The following is a description of a gene set: species: Mus musculus Genes predicted to be targets of miRBase v22 microRNA mmu_miR_6373 in miRDB v6.0 with MirTarget v4 prediction scores > 80 (high confidence targets). Mouse Gene Set: MIR_6373 from publication Chen Y, Wang X (PMID 31504780), and this is the list of marker genes: Rusc1, Tmem245 (transmembrane protein 245), Tsc1, Srprb, Smim17, Fgfr1op2, Nkapd1, Mrgpra3, Ccnc, Lrfn5, Zfp287, Bms1, Klf1, Ncam2 (NCBI Gene Id 18257), Trim30a, Impact, Spag16, Ablim3, Oosp1, Hagh, Tub, Rgs5, Capn6, Tm4sf4, Grin2b, Sh3bgrl, Thrb, Zfhx3, Slc38a1, Golga5, Neurog2, Acbd5, Igll1 (immunoglobulin lambda-like polypeptide 1), Faf1, Usp43 (ubiquitin specific peptidase 43), Nptx1, Pcgf3, Kmt5b, Abitram, Myh10, Bmp15, Twf1, Sp4, Gpr141b, Rad51ap1, Hook3, Thsd7b, Tmem106b, Lancl3, Clcn5, Dach2, Virma, Lgi1, Ska2 (spindle and kinetochore associated complex subunit 2), Rnf19a, Gng2, Trabd2b, Camk4, Ndst2 (NCBI Gene Id 17423), Tmed5, Pkia, Lmbr1, R3hdm2, Mapkap1, Nlrp4f, Vit, Sod3, Ttpal, Sun2, Tigd3, Skida1, Cherp, Slc30a6, Brpf1, Asb7, Cdc73, Maz, Tmem45a2, Pdk3, Gtdc1, Vax1, Tmx1, Tnfsf11, Mcm4, Ammecr1, 6030468B19Rik, Snx25, Fndc3b, Zfhx4, Kdm7a